The following is a description of a gene set: species: Mus musculus Any process that activates or increases the frequency, rate or extent of translational elongation. Mouse Gene Set: GOBP_POSITIVE_REGULATION_OF_TRANSLATIONAL_ELONGATION, and this is the list of marker genes: Eif5a2, Secisbp2, Eif5a, Usp16 (NCBI Gene Id 76164), Smyd5